Given this list of marker genes Htr1b (5-hydroxytryptamine (serotonin) receptor 1B), Htr2b, Htr1f, Htr2a, Htr3a, Htr1a, Slc6a4 (solute carrier family 6 (neurotransmitter transporter, serotonin), member 4), Htr4, Htr2c, Htr1d, Maoa, here is a description of the gene set: Binding to serotonin (5-hydroxytryptamine), a monoamine neurotransmitter occurring in the peripheral and central nervous systems, also having hormonal properties. Mouse Gene Set: GOMF_SEROTONIN_BINDING species: Mus musculus